The following is a description of a gene set: Human Gene Set: HP_DECREASED_CIRCULATING_CERULOPLASMIN_CONCENTRATION studied in species Homo sapiens Decreased concentration of ceruloplasmin in the blood. Decreased circulating ceruloplasmin concentration, and this is the list of marker genes: ATP7B, AP1B1, COG2, TMEM199, CCDC115, AP1S1, ATP7A, SLC33A1, CP (ceruloplasmin)